Given this list of marker genes NANOG, LEFTY2, MYC, NODAL, LEFTY1 (left-right determination factor 1), CRIPTO, POU5F1, here is a description of the gene set: Genes down-regulated in hES cells (human embryonic stem cells) after treatment with the ALK inhibitor SB-431542. The application of human embryonic stem (ES) cells in medicine and biology has an inherent reliance on understanding the starting cell population. Human ES cells differ from mouse ES cells and the specific embryonic origin of both cell types is unclear. Previous work suggested that mouse ES cells could only be obtained from the embryo before implantation in the uterus. Here we show that cell lines can be derived from the epiblast, a tissue of the post-implantation embryo that generates the embryo proper. These cells, which we refer to as EpiSCs (post-implantation epiblast-derived stem cells), express transcription factors known to regulate pluripotency, maintain their genomic integrity, and robustly differentiate into the major somatic cell types as well as primordial germ cells. The EpiSC lines are distinct from mouse ES cells in their epigenetic state and the signals controlling their differentiation. Furthermore, EpiSC and human ES cells share patterns of gene expression and signalling responses that normally function in the epiblast. These results show that epiblast cells can be maintained as stable cell lines and interrogated to understand how pluripotent cells generate distinct fates during early development. species: Homo sapiens Human Gene Set: TESAR_ALK_TARGETS_HUMAN_ES_5D_DN from publication Tesar PJ, Chenoweth JG, Brook FA, Davies TJ, Evans EP, Mack DL, Gardner RL, McKay RD (PMID 17597760)